The following is a description of a gene set: species: Homo sapiens Human Gene Set: TET1_TARGET_GENES from publication Yevshin I, Sharipov R, Kolmykov S, Kondrakhin Y, Kolpakov F (PMID 30445619) Genes containing one or more binding sites for (TET1) in their promoter regions (TSS -1000,+100 bp) as identified by GTRD version 20.06 ChIP-seq harmonization., and this is the list of marker genes: CNPY2, PPP4R3B (protein phosphatase 4 regulatory subunit 3B), NANP, ETHE1, GPR108 (NCBI Gene Id 56927), TNPO1, PRSS35, CDCA5, DECR2, TNIK, TTC32, IQCG, STRIP2, SETDB2, CTR9, ASIC1, PLS1, TACO1, ACAP3, ZSWIM4, MAZ, CLCN7, CYRIB, TMEM169, LSM2, NAA35, ACAN, ENSG00000271860, EIF1AY (eukaryotic translation initiation factor 1A Y-linked), ZNF410, YY1, TRAF3IP2-AS1 (NCBI Gene Id 650970), ZNF747-DT, LMX1B, ANXA4, TMEM200C, TDRKH-AS1, RPP40, RBMXL1, LTV1, SRP19, ADGRV1, ATP8A2, NCDN, CAND2, ATP8A1-DT, LTBP4, SPTLC1, CACYBP, GARNL3, AGFG2, NALF1, CCT7, PFKFB2, GPX1, ARFGAP2, ABHD17B, LMX1B-DT, SFXN3, ZNF850, EIF5, BDNF-AS, SFR1, MALAT1, PIGC, DAZAP2, FOSB, WDR19, PANK1, CHRNB4, MIF4GD-DT, SELENOH, PPCDC, NDUFB1, DGAT1, ENSG00000246465, UBR4, RICTOR, MRPL48, LSM5, MIR6892, DNAJC24, BRPF1, SPDL1, GTF3C6, HSBP1, ACOT7, LIPE-AS1, DPP9, ACTN3, GINS1, ENSG00000245651, RAD21, RAD51AP1, C9orf85, POU4F1, RPS6KB2, SLC27A6, SELENOV, DTX4, TTC23, NR2C2, ATP5F1C, TMEM254-AS1, RGS5, ZNF286A, NKTR, PRPF3, PPP1R15B, MRPL27, ATG16L1, CASP9, BRD2 (NCBI Gene Id 9803), G2E3, RPS24, RANGAP1, NDUFA7, HECTD3, TMTC4 (NCBI Gene Id 94896), EMC8, AGA, DGCR8, TBC1D14, EME1, UBE2A, MTCP1, TSPAN31, EFHC1, LINC01902, ARHGEF12, LHX1, GALNT17, TXNL1, GPATCH4 (G-patch domain containing 4 (gene/pseudogene)), HEXIM1, MIR129-2, PRKAG2, GEM, ACADSB, FHL1P1, SVEP1, PFDN4, ZIC4, RPS26, ZNF487, TMEM258, ARL6, RASSF1, PCMTD1, COX7B, ELAC2, ME2, MYEF2, PLEKHG2, PIPOX, PRKAG2-AS1, ARPC4-TTLL3, WNK3, RNVU1-2A, ABRAXAS2, SARAF, SNX1, BZW1, TRIM23, C5orf52, SRRM2, EMC1, SNX10-AS1, POC5, TOMM20, MED21, PPM1K-DT, LANCL2, SLC35D1, SENP8 (NCBI Gene Id 123228), LRSAM1, AKAP11, MRPL51, RMND1, SMDT1, SPC25, HJURP, RAD9A, NDUFA12, BUD23, GMPPA, HYDIN, SRRM2-AS1, CARMIL1, PLAG1, NAE1 (NEDD8 activating enzyme E1 subunit 1), NEXN (NCBI Gene Id 91624), STRIP1, LINC02980, H2AZ1, KIF1C, SLC29A1, AKAP1-DT, RDM1P5, SEC61A1, GSPT1, STMN3 (NCBI Gene Id 50861), PSMD5, PCCB, MKKS, OCRL, TMEM266, GPR161, TRIP10, EIF2D (eukaryotic translation initiation factor 2D), KIN, MTF2, SMARCD2, INTS11 (integrator complex subunit 11), MIR4638, ZFC3H1, RBM39, STK40, SLCO3A1, CENPH, HDDC2 (HD domain containing 2), VPS16, ARSK, CAND1, STARD7, PDCD7 (programmed cell death 7), HAPLN4, GGA3, KIAA1586, NOP14, UBE2F, SHARPIN, DOCK3, RPL26L1-AS1, CAMLG, TOMM7, RAB1A, ZKSCAN7, CNDP2, PTK2B, NOL3, BARX1, UPF3A, KDM1B, RASAL2, SNORD1C, CDC5L, ALG10, NIN, TAS2R14, PDHX, COPG2 (NCBI Gene Id 80038), PEX16, PDE8A, TRMT1L, CFAP410, TTC21B, AGL (NCBI Gene Id 178), GTF2IP12, RGMA, RPL23A, UGP2, C6orf89, TSC22D2, TYW5, ZNF793-AS1, KYAT3, SMNDC1, WNT9B, EXOSC9, UBXN4, HS2ST1, EDC4, NKAPD1, NTNG2, ZEB2-AS1, ACOT13, H3C11, DGCR2, VEZT, TNFRSF11B, SLF1 (SMC5-SMC6 complex localization factor 1), DNAJC27-AS1, CCT8, PPP2CA-DT, KIF3B, INKA2, FOXN2, VPS26B, UCK1, UCHL1-DT, EIF2A, PMF1-BGLAP, TCEANC2, ARF3, JAG1, AGBL3, RBM15, LINC01833, FAM110B, DCTN1, HCG14, EIF3D, DCAF8, PPM1K, ATF7IP, TM9SF4, NSL1, ERICH6-AS1, SIX4, PLA2G4C, BCAR3, DRG2, ABHD16A, IREB2, RTTN, RWDD1, CSPP1, ENSG00000232995, MACF1, PTPN1, GOSR2-DT, CDC25A, SRSF3, MAPKAPK5-AS1 (NCBI Gene Id 51275), COPS7B, KLHL8 (NCBI Gene Id 57563), UROD, SWT1, TMEM209, RFC5 (replication factor C subunit 5), PRKAG1, SNRPE, TSPAN12, RPS4X, ZMYM6, CD37 (NCBI Gene Id 951), CNOT11, IMMP2L, KIAA0930, SKA3, VMP1, MVB12A, INCA1, ABCD3, YBX3, OXR1, TMEM222, TP53, TDP2, ZNF568, TRIM36, OXR1-AS1, PUF60, ZNF189, EGFLAM, PDZD7, RPL24, PRLHR, HPSE, MYLK-AS1, TADA3, RUFY2 (RUN and FYVE domain containing 2), NEO1, ENPP3, VDAC3, PLD3, DAB2, RPL3, PGAP4, SLC50A1, TLE4, SPTB, FCSK, PCDHGC4, MPP7-DT, HAUS2, SF1, XPC, RPL27, SEC62, RAPGEF2, KCNN2, NFIB-AS1, ITGAE, NCAPG, BANK1, CALCB, MAX, BORCS5, MED23, FGD6, COA7, FBXO38-DT, ELMOD2, ATR, TARDBP, SOX30, TPMT, RMDN1, CDCA7 (NCBI Gene Id 83879), NSUN3, DCDC1, SLC25A11, ZNF547, PTGES3, DCBLD2, ATF7-NPFF, TP53RK, OGFOD2, FDPS, ANGPTL6, UCHL5, STX18-AS1, SLC12A8, STAG3L5P-PVRIG2P-PILRB, ARHGEF3, SEC22C, RNASEH2C, SMIM13, DLEU1, WDR36, ADISSP (NCBI Gene Id 54976, adipose secreted signaling protein), DNAJC27, PELI3, NPY5R (NCBI Gene Id 4889), GASK1A, ENSG00000225420, ZNF544, POLL, RAD54L, ENKUR, SSH2, SREK1, PRDX1, RPRD1A, PURG, ZNF131, ANKRD54, ANKH, TRAPPC13, NBPF25P, CPSF2, PCSK7, PDE6D, MEST, CACNB2, GRK4 (NCBI Gene Id 2868), VMAC (NCBI Gene Id 400673), TNFRSF21, GSEC, PDZRN3, C17orf75, NPTN, AP1B1 (NCBI Gene Id 162), SNX2, RNF225, MRPS23, MAPK14, SRFBP1, H4C8, BTG2-DT, GTF3C5, TDRKH, ZDHHC24, STX18, HLA-DMA, NEK1, GAS8, MYO9A, SMAD4, NSA2, NR2F2-AS1, NDUFAF1, SERP1, RPS11, ZYG11A, WASHC4, ING4, SAMD8, GPR89A, ZNF846, NEK2-DT, PTTG1, HS6ST3, CTDP1, NPM1, ORAI3 (ORAI calcium release-activated calcium modulator 3), NELFE, CTTNBP2, MTHFD1, CNIH3, TAOK2 (TAO kinase 2), OGFOD1, ARHGEF39, NUDT21 (nudix hydrolase 21), RAD23B, CNP, ZNF829, SNX11, ONECUT1, CCNC, FBXL5, TMEM217, RAB32 (RAB32, member RAS oncogene family), ZFAND2A-DT, NOL11, GATA6-AS1, TANK-AS1, ALKBH3, CKAP2, SNORA14B, MFN2, AGO2, ZKSCAN5, GAPVD1, GATAD2A, GPX8, MRPL50, RDM1, PGBD1, AURKAIP1, DNAJC30, TJAP1, RNF167, DUSP28, MICOS10-DT, GCA (NCBI Gene Id 25801), PIGX, TSTD2, LAMC1, METTL25, NFYB, STX5-DT, BIRC2, NEMP1, ZCCHC8, HUWE1, PHF12, GPM6A, TSPYL1 (TSPY like 1), BARX1-DT, CHTF18, ABCB9, SMIM2-AS1, H4C2, WDR70, GALNT13, ICA1-AS1, ZZZ3 (NCBI Gene Id 26009), NUF2, PDIA4, SYNRG, TNS3, RASAL2-AS1, PRH1 (NCBI Gene Id 5554), GFPT1, BCL6, MEF2B, FUS, ARFGAP3, TOM1L2, OSBPL2, TIMM9, MICOS10-NBL1, RSPH3, GOSR1, MIS18BP1, TERC, SMARCE1, MIR5695, TMOD3, PEX26, LCMT1-AS1, SLC39A3, VPS13B, ASXL1, SLC12A2, TADA1, ENSG00000236543, BCL2L12, FOXP4, LRRC57, TRIM41, ERICH6, ST3GAL4, RPS15A, PPP1CC, CEP19, PARP6, RANBP6, MORF4L2, TASOR2 (transcription activation suppressor family member 2), SART1, TTC7B, HIVEP1, OFD1, H4C12, RPL35A, NONO, METAP1, WARS1, C1orf105 (NCBI Gene Id 92346), CA9, EPS15L1, ISOC2, QTRT1, ZNF529 (zinc finger protein 529), ITFG2-AS1, SLC43A1 (NCBI Gene Id 8501), PCTP, TCF3, SNHG16, MIR4787, FBXO7, GALK2, ELK4, DCAF16, SNRNP70, RNF187, HMGB3, COPB2-DT, ARPC4, YY1-DT, QRSL1, RPS3A, C9, NAV2, TRIM35, DST, MRM3, CRBN, LINC00237, TTLL12, SDCBP, MAP3K13, MTMR9LP, FAM219A (NCBI Gene Id 203259), JOSD2, SORD, SNHG30, PSMF1, ARHGEF40, MARCHF7, ZNF839, CAB39L, CHCHD7, COX4I1, CUX2, H2AZ2-DT, CASC3 (CASC3 exon junction complex subunit), RAP1GAP2, PREX2, ZCCHC4 (NCBI Gene Id 80001), MICOS10, OXNAD1, CHAF1A, MIR3928, ZNF614, YJU2B, KYAT1, PDLIM7, MCM6, MED26 (NCBI Gene Id 9441), DHX37, SHLD3, MIR3678, IFT25, FRMD3-AS1, CABLES2, MPHOSPH6-DT, CUL3, PPP1R35, RPL26L1, TMEM39B, MYO3A, TFAP2A, ZFAND2A, MORF4L2-AS1, FGD5-AS1, ENOSF1, B4GALNT3, RPS28, CNPPD1, UBE2I, CFLAR, MED1, NUP37, LARP4, MRPS7, TCF4, RPL29, ATP6V1H, ANLN, KIAA0825, CHFR-DT, CHD7, NINL, GYS1, GRM1, BCLAF1, RAD50, POLE, SMG5, PCED1A, ENSG00000267260, CTTNBP2NL, MPHOSPH6, RIBC2, DDIAS, SSR1, NFKB2, FTH1, ZBTB42, MRTO4, CCNG2, PITPNC1, MZT2B, NREP, MCM9, SPAG16, ZNF174, TRIM68, PIGN, IKBKG, UBR3, MDH2, TRAPPC2, SIKE1, CREBZF, POLR1A, BSCL2, DHX15, PDRG1, EHHADH, HDHD2, TIMM22, TBC1D8, HMGCS1, NDUFAF4P1, LOH12CR2, TMCC2, ZFYVE27, SMIM20, ARHGEF4, IMP3, ZNF771, MRPL57 (mitochondrial ribosomal protein L57), HERC1, C5orf24, PKIA, NCAPD2, COPS8, FANCM, RAB11FIP4, LRRC28, PSMC3IP, ZNF554, H2AZ2, TANK, MOB1B, ATP7B, WDR11, NDUFS7 (NADH:ubiquinone oxidoreductase core subunit S7), FSIP1 (NCBI Gene Id 161835), LIN7C, ZNF548, TMEM79, DROSHA, MRPS31, BBX, SNORD43, CPNE4, C14orf39, PIH1D2 (NCBI Gene Id 120379), POLR3D, TUBGCP5, TTYH1, EMC1-AS1, NAA38, TMEM237, TXNDC17, RNU6-7, RASGEF1B, RPS9, SELENOF, TNRC6B, SNORD42B, CHUK-DT, SMPD1, CDK12, HSPBP1, TNRC6A, AURKB, MRPS14, PPFIA2, PTH1R, PDHB, MIF4GD, KLHDC10, HNRNPH3, RPS7, CAD, RPL5, CALB2, CDC6, RC3H2, ITPKA, PLA2G12AP1, TMX1, DZIP1L, ZNF77, GRB2, CPTP, RPL18A, MTMR4, CUL4B, SCCPDH, ZFPL1, FBXO38, CKAP2-DT, PECR, AKAP1, DRC3, RNU5A-8P, PPP1R12A, MNT, DPY19L4, CSNK1G3, RHOG, LHFPL4, WARS2-AS1, APIP, OTULINL, GDI2, LARP7, SBNO1, AGPS (alkylglycerone phosphate synthase), OSBPL1A, TRMO, BUD13, FBXL13, BANP, MTFR1, MPND, HAND2-AS1, ERBIN-DT, IRF3, CTCF (CCCTC-binding factor), CHUK, TOMM22-DT, WDR25, EZR, ALG11, CUL2, XPO1, CARD8, SLU7, NUP210 (NCBI Gene Id 79985), NCOA4, SMC4, BRCC3, DKKL1, ZSCAN25, RNF20, WDR26, RPL30P11, RAB6A, DLG4, RBBP9, PPP4R3B-DT, TOPBP1, IL23A, TMEM254, IBTK, FRYL, MAPK4, TFAP2C, UQCC1, MICOS13, ZNF335, PPFIBP1, ANKMY1, REV3L, FAM222A, FADS2, SAC3D1, NTM, LRRC42, ZKSCAN2-DT, MYL3, ERCC6L2-AS1, SEPSECS-AS1, CCDC83, DNAAF3, TAB3, RNF185, GRPEL2, TMEM18, KIAA0753, RNF214, MEMO1, PARAIL, TATDN1, ILF2, KIAA0319L, RPS6, SPAG8, DENR, THNSL1, KIAA0586, ZNF300, PDE4D, DDX1, ZNF224, CDRT15P3, PXMP2, ADAT1, USP54, EIF4A1, TOMM22, YTHDF2, CFAP77, ICA1, TPRKB, COPS2, FNDC3A (fibronectin type III domain containing 3A), ACYP2, ZNF793, EVX1, TMEM199, NCAPD3, C19orf47, LINC02029, UBE2F-SCLY, FAM200B, GFM2, NOX4, RPS19, MTFMT, FAM111A, HACD2, DNAH2, TRERF1, PHRF1, NEK2, SC5D, SLC15A4, ATF7, CERS2, COPS5, FNIP2, POLA1, UCHL1, STAG3L5P, FAM135A, SLC12A2-DT, MRPL45, SKIC2, DHX40, NFATC2IP, SAMD1, ERICD, LETMD1, PTGR2, AP1G1, CCDC59, RPL36, TMEM33, MANBA, KCTD13-DT, GLRX3 (glutaredoxin 3), OARD1 (NCBI Gene Id 221443), TP53RK-DT, RFESD, HAGH, ADM2, CLCN3, CLIC4, THADA, MON2, SKIC3, TMEM44-AS1, C2orf42, EIF4A2, METTL2B, USP16, FERRY3, TNRC6B-DT, FOXD1, PIK3R3 (NCBI Gene Id 8503), CENPU, GLOD4, SSBP3, TBC1D19, CBX7, ERCC6L2, CYB5D1, ATE1OSP, PRR4, PKIB, TMEM9B-AS1 (TMEM9B antisense RNA 1), PXYLP1, BMS1, SPRTN, ITFG2, WDR77, ATP5PB, RGS9, COPS7A, PDZD2, ENSG00000233030, MAGOHB, WARS2, FKBP3, NFU1, ZEB2, NFE2L2, MYC, G6PD, RANBP10, IFT80, RAPGEF6, HSD11B1L (NCBI Gene Id 374875), ZNF286A-TBC1D26, CENPA, SUMO2, CTNNA1, MED11, EFCAB2, PRKACB-DT, TAF7, HMCN1, NCBP1, LYRM2, RO60, ZNF805, NFIB, THEM4, THNSL2, PPP2CA, TIPRL, RHOT1, TUBB4B, NDUFA4, UBE2Q2, FAHD1, PSTK (NCBI Gene Id 118672), CRTC1, RBM25, SEPTIN7P14, SF1-DT, DPCD, STAP2, GSAP, ZNF337-AS1, RPE, CCDC8, SPNS1, SSBL4P, SLC25A35, NUDT2, ABCF1, TRDMT1 (NCBI Gene Id 1787), KLHL3, PPP2R3B, PPM1G, SMARCA5, RTN4IP1, C5orf22, RGL2, TMEM115, PLAC9, PI4K2A (phosphatidylinositol 4-kinase type 2 alpha), SELENOT, FXYD5, CTH, AMN, PGM1, H2AZ1-DT, ARMT1, EXOC8, TRIM69, SF3B5, CFL1, BCAT2, RPS27, LMBRD2, MAP3K7, FLJ16779, PROM1, CFAP418, PLSCR2, STIL, FAM66C, TPM4, NATD1, C1orf74, GATAD1, ATF2, TAF12, KIZ (NCBI Gene Id 57166), GOSR2, VPS13B-DT, SPAG16-DT, PRPSAP1, NR2C1, HSPA4, ZSCAN23, RCAN1, CDC42BPA, STK17A, CMAS, BUD13-DT, PIK3R2, FAM200C, SIPA1L1, RXRG, MRPL22, MMS22L, TRAPPC2B, NOL4, MAF1, ZNF329, DPH3, C20orf96, THAP2, SDHB, ARHGAP26, GATA4, INVS, MIDN, COPS8-DT, RPL10A, TAGAP-AS1, PYROXD1, KCTD13, EML6, GALK1, GPR89B, DNM1P35, TRMT1, GATA6 (GATA binding protein 6), ATE1, MAIP1, YOD1, ZYX, STYXL1, GPR6, WDR11-DT, ASH2L, PAN2, MIR933, LRRC8E, PMF1, EPB41L2, ENSG00000279561 (NCBI Gene Id 124906883), NFYA, ZGRF1, ALKBH8, VTI1B, NBPF12, COL9A1, CENPV, TOR1AIP1, ZRANB3, TUBB2B, LACC1, COG2, ZFAND6, IGSF9, PARPBP, ADPRH, TMEM132A, TRPC7, CLP1, LRP6, ZNF260, PTRH2, BOLA1, CCDC14, CDK11A, TIA1, ETFA, IPO9-AS1, ANKFY1, TAF12-DT, ERGIC2, TMEM120B, TMEM38B, TARS2, SYCE2, RNPC3-DT, MIR3912, SKP2, PCDH9, MATCAP2, MTRF1L, LCMT1, LIN7B, RNPC3, CYTH2, TUBG2, SRSF10, SLC17A7, BTF3L4, BEND3, ABI1, COASY, DSE, PSME4, SMC1B, IL5, CSTF2T, PIP5KL1, ETF1, MTCO3P12, CHFR, TXNDC12, SLX4IP, COPB2, LDHA, EDA, CNIH2, RPL12, ZNF136, ZSCAN32, MERTK, TMEM41B, LRP1, TSNAXIP1, OIP5-AS1, NDUFB9, JAKMIP2, SIRT1, EPHB4, PDXDC1, ARL1, COIL, FOXP4-AS1, SELENON, AFF1, ZNF529-AS1, AKT3, MLLT1, FMO5, SLC25A16, ZNF787, TTC32-DT, PCMTD1-DT, RUVBL2, POM121 (POM121 transmembrane nucleoporin), NKAIN4, ENSG00000282936, EPG5 (ectopic P-granules 5 autophagy tethering factor), CNOT3, CFAP206, TMEM9B (TMEM9 domain family member B), ROGDI, MECOM, MAPKAPK5, GTPBP3, NDUFA11, RALY, C4orf3, KIF22, SHPRH, ZC3H4, TYMSOS, TYRO3 (NCBI Gene Id 7301), TBC1D22B, ZNF675, TEX9, DHFR2, CWC22, ARHGEF4-AS1, SAE1, ZNF782, ZKSCAN2, INHCAP, TLL2, FEN1, PITPNM2, RIPK2, QRICH1, TTBK1, ZNF714, PUSL1, AKR1B1, LRRC8A, RPUSD1, PDE4A, SCRN2, WBP1L, CDH13-AS2, PPP1R42, ANAPC5, MCOLN3 (NCBI Gene Id 55283), CSNK1G1, NEDD1, HNRNPH1, BNIP2, IKZF5, PAIP1, DMAP1 (NCBI Gene Id 55929), MIR320A, TATDN3 (NCBI Gene Id 128387), NFYC, POLDIP2, SMIM27, NOTCH3, RELCH, DNAI1, NAP1L4, TXNIP, USP47, TMEM59, ENSG00000213963